The following is a description of a gene set: A type of gait ataxia displaying progression of clinical severity. Progressive gait ataxia Human Gene Set: HP_PROGRESSIVE_GAIT_ATAXIA species: Homo sapiens, and this is the list of marker genes: TPP1, TWNK, SCN2A, FA2H, CACNA1A, GABRA1, MTPAP, PSAP, MT-ATP6, PEX10, SCN9A, GABRG2, EEF2, PRRT2, SACS, ARSA, UBE3A, ANO10, SNRPN (small nuclear ribonucleoprotein polypeptide N), ALDH18A1, PCDH19, GJB1, SCN1A, POLG, SPTBN2, SETX, ATP13A2, SCN1B (NCBI Gene Id 6324), ATXN3, ATP1A2